The following is a description of a gene set: Human Gene Set: ETF_Q6 Genes having at least one occurrence of the motif GVGGMGG in the regions spanning 4 kb centered on their transcription starting sites. This matches the transcription factor binding site V$ETF_Q6 (v7.4 TRANSFAC). species: Homo sapiens, and this is the list of marker genes: COP1, H3-3A, POMGNT1, PRKACB, PPP3CB, CHAT, SRRM1, ST6GALNAC5, TSPAN2, RPRD2, C1orf43, DR1, HMGN2, SUV39H2, FAM76A, UBR4, FOXD3, SPATA6, KPNA6, ZEB1, SLC18A3, KCNQ4, ZNF644, SKIDA1, ARID1A, CAMK2G, CMPK1, LAD1, CSGALNACT2, KCND3, CLSTN1, LINC01138, MIER1, RNF2, ATXN7L2, LRRN2, TMEM222, RUSC1, MAN1C1, CDC73, STAM, RASAL2, ASH1L, USP21, ZBTB41, RO60, PITHD1, ELK4, FAF1, CAMK1D, SCYL3, HPCAL4, GNB1 (G protein subunit beta 1), RXRG, CUL2, KIAA2013, C1orf21, CRTC2, YY1AP1, WNT3A, ZNF687, PRDM16, XPR1, SSBP3, RGS8, DAP3, CELSR2, ZSWIM8, RNF220, LRP8, KIF17, DNAI4, WAC, SLC41A1, CCDC6 (NCBI Gene Id 8030), ZFYVE9, RRAGC, UNC5B, CCSAP, GRIK3, AGO1, ZNF362, YTHDF2, TENT5C, MIR137HG, ARTN, CTNNBIP1, SOX13, EPC1, MTOR, ZNF281, DCAF8, EMC1, MFN2, VAMP3, ZBTB17, USP48, RERE, FAM13C, POU2F1, MCU, AGO3, MAST2, KDM1A, CACNA1E, RAP1GAP, MRTO4, BMI1, YBX1, UCHL5 (NCBI Gene Id 82736), LMO4, NFYC, CDC7, NFIA, EFNA3, ZNF496, TRIM33, PHF13, MARCKSL1